Given this list of marker genes Foxa1, Vps18, Strn3, Vps11, Cnot2, Parp1, Ufsp2, Foxh1, Carm1, Kmt2d, Phb2, Ar, Cyp7b1, Skp2, Ufl1, Lats1, Uba5, Dnaaf4, Wbp2 (NCBI Gene Id 22378), Cnot9, Fshr, Kank2, Med1, Ncoa3, Src, Zfp366, Pak1, Cnot3, Cnot1, Srarp, Ufm1, Isl1, Lbh, Brca1, Pagr1a, Trp63, Ddrgk1 (NCBI Gene Id 98926), here is a description of the gene set: Any process that modulates the frequency, rate or extent of the activity of an intracellular estrogen receptor signaling pathway. studied in species Mus musculus Mouse Gene Set: GOBP_REGULATION_OF_INTRACELLULAR_ESTROGEN_RECEPTOR_SIGNALING_PATHWAY